Given this list of marker genes PKD1, CAMK1, HDAC3, RANBP3 (NCBI Gene Id 8498), XPO7, YWHAE, PRKD1, SIRT7, BARD1, RANBP3L, PARK7, XPO4, PTPN14, TXN, PRKACA, IFI27, RANGAP1, STRADA, SMURF1, UHMK1, XPO1, IL1B, DESI1, CSE1L (NCBI Gene Id 1434), NXT1, XPO5, CALR, PTPN11, TGFB1, CCHCR1, SP100, PPM1A, NUTF2, SFN, GSK3B, XPO6, EMD, NUP42, STRADB, RBM22, BAG3, MDM2, CTDSPL2, RANBP17, AHCYL1, GAS6, RAN, RAPGEF3, CDK5, CDKN2A, FAM76B, ANP32B, EGR2, FRAT2, CHP1, SIRT6, HSPA9 (heat shock protein family A (Hsp70) member 9), PRP4K, FRAT1, NUP214, ANKLE1, ADAR, TPR, here is a description of the gene set: The directed movement of a protein from the nucleus into the cytoplasm. Human Gene Set: GOBP_PROTEIN_EXPORT_FROM_NUCLEUS studied in species Homo sapiens